Given this list of marker genes Grid2, Rhoa, Ntn1, Wnt7a, Lingo2, Ntng2, Flrt2, Mef2c, Dock10, Asic1, Ntrk1, Amigo3, Mdga2 (NCBI Gene Id 320772), Nrg2, Slit2, Gna13, Ppp1r9b, Srcin1, Lrtm2, Wnt5a, Zdhhc8, Cpeb3, Vstm5, Dock4, Fzd1, Map1b, Slitrk2 (NCBI Gene Id 245450), Cbln2, Crtac1, Snap25, Carmil3, Setd5, Flrt1, Arhgap33, Cript, Chrnb2, Lrrtm1, Rap2a, Afdn, Lin7a, Nectin1, Usp9x, Thbs2, Lrfn3, Grin1, Prickle1, Adgrl1 (NCBI Gene Id 67271), Ephb1, Rtn4r, Slitrk5, Slitrk6, Iqsec1, Abi3, Syndig1, Adgrb3, L1cam, Ctnnb1 (NCBI Gene Id 12387), Nrxn1, Ube3b, Nectin3, Lin7b, Amigo2, Elavl2, Eif4g1, Il1rap, Nlgn2, Lrrc4b, Rtn4, Pum2, Slc12a5, Nckipsd (NCK interacting protein with SH3 domain), Vps35, Xlr3b, Lin7c, Ube2m, Ptpn1, Mark1, Snca (synuclein, alpha), Ptprd, Lzts1, Il1rapl2, Oxtr, Lrrn1, Iqgap1, Six1, Gsk3b, Neurl1a, Trim47, Vldlr, Efnb3, Dlg4, Crmp1, Ube2v2, Lats1, Lrfn4, Farp1 (FERM, ARH/RhoGEF and pleckstrin domain protein 1), Mdga1, Gpc4, Dock1, Abi3bp, Icam5, Adgre5, Ephb3, St8sia2, Numbl, Dkk1, Musk, Srgap2, Wnt3a, Clstn3, Epha7, Cux2, Tlr2, Cyfip2, Cbln1, Ptk2b, Robo1, Lrp4, Flrt3, Lrrtm3, Adgrl4, Slitrk3, Adgrl2, Fgfr1, Pik3r1, Actr3, Bdnf, Ntrk3, Dlg5, Ogt, Nae1, Lzts3, Podxl, Lhfpl4, Rac3, Rac1, Eef2k, Ntrk2, Prickle2, Adnp, Lrfn5, Psd, Amigo1, Il1rapl1 (NCBI Gene Id 76162), Sipa1l1, Asic2, Clstn2, Clstn1, Sema4c, Colq, Dclk1, Sema4a, Nrxn2, Nrg1, Rab17, Adgrb1, Slitrk1, Srpx2, Nlgn3, Stau2, Agrn, Adgrb2, Ptpn13, Rhog, Ptk2, Negr1, Adgrl3, Caskin1, Iqsec2, Lingo4, Six4, App, Ephb2, Lrrtm2, Lrrn3, Dcx, Nedd8, Numb, Ppp1r9a, Tpbg, Arf6, Slit1, Lrrc24, Sema4d, S1pr2 (NCBI Gene Id 68430), Lrrtm4, Igsf11, Sigmar1, Fam107a, Srgap3, Cc2d1a, Ghrl, Bhlhb9, Lrfn1, Chd4, Oxt, Pdlim5 (NCBI Gene Id 99766), Arhgef15, Mycbp2, Elmo1, Efna5, Pdzd11, Slitrk4, Lrtm1, Ghsr, Prkca (protein kinase C, alpha), Nlgn1, Ptprs, Htr4, here is a description of the gene set: Mouse Gene Set: GOBP_REGULATION_OF_SYNAPSE_ASSEMBLY studied in species Mus musculus Any process that modulates the frequency, rate or extent of synapse assembly, the aggregation, arrangement and bonding together of a set of components to form a synapse.